Given this list of marker genes Scn2a, Itpk1, Ldb2, Kit, Fezf2, L1cam, Adcyap1, Galnt10, Sphkap, here is a description of the gene set: studied in species Mus musculus Genes selectively expressed by cells fated to differentiate as subcerebral projection neurons in embryonic day 14.5 mouse cortex. Mouse Gene Set: HEVNER_CORTEX_COMMITTED_TO_SUBCEREBRAL_PROJECTION_NEURON_FATE from publication Bedogni F, Hevner RF (PMID 34321999)